The following is a description of a gene set: Digestion and absorption Mouse Gene Set: REACTOME_DIGESTION_AND_ABSORPTION studied in species Mus musculus, and this is the list of marker genes: Amy2a5, Slc2a5, Gucy2c, Amy2a4, Chia1, Guca2b, Pnliprp2, Sis, Chit1, Guca2a, Slc5a1, Cel, Pir, Amy2a2, Lct, Slc2a2, Pnliprp1, Pnlip, Mgam, Alpi, Amy2a3, Clps, Npc1l1, Lipf